The following is a description of a gene set: Any process that increases the rate, frequency, or extent of brown fat cell differentiation. Brown fat cell differentiation is the process in which a relatively unspecialized cell acquires specialized features of a brown adipocyte, an animal connective tissue cell involved in adaptive thermogenesis. Brown adipocytes contain multiple small droplets of triglycerides and a high number of mitochondria. Mouse Gene Set: GOBP_POSITIVE_REGULATION_OF_BROWN_FAT_CELL_DIFFERENTIATION species: Mus musculus, and this is the list of marker genes: Mecom, Pim1, Ptgs2, Ffar4, Prdm16, Zbtb7b, Mapk14, Hnrnpu, Six1 (NCBI Gene Id 20471), Bmp7, Fndc5, Vstm2a, Tfe3, Sox13, Napepld, Rreb1, Metrnl